Given this list of marker genes Trpv1, Ppp3ca, Crh, Pomc, Gabra1, Arc (activity regulated cytoskeletal-associated protein), Htr2c, Camk2b, Htr1a, Fmr1, Adra1a, Plcd4, Eef2, Fos, Grm1, Prkcb, Plek, here is a description of the gene set: species: Mus musculus Mouse Gene Set: WP_SEROTONIN_AND_ANXIETY Serotonin and anxiety